Given this list of marker genes BCL7B, TMEM161A, H2AX, NFRKB, SMARCD1, SHLD1, BABAM1, ARID1A, SPIRE1, CBX8, SMARCD2, BRCA1, INO80C, ACTB, EYA3, EGFR, ACTL6B, KAT5, EPC1 (enhancer of polycomb homolog 1), FH, SLF2, SIRT6, FAM168A, CYREN, KMT5C, SIRT1, CEBPG, UBE2V2, SMARCB1, EYA4, BABAM2, SPIRE2, SMARCA2, CREBBP, MARCHF6-DT, TOP2B (DNA topoisomerase II beta), SMARCA4, PNKP, WRAP53, VPS72, ACTR8, NBN, ATM, RUVBL2, ERCC8, PRKDC, MRE11, RPS3, UIMC1, PHF10, MORF4L2, CCDC117, EYA1, RNF8, DPF2, YEATS4, PIAS4, INO80E (NCBI Gene Id 283899), PCNA, HELQ, SHLD3, DMAP1 (NCBI Gene Id 55929), UCHL5, MCRS1, TIGAR, FMN2, BRD8, DPF1 (NCBI Gene Id 8193), SMARCD3, NPAS2, WDR48, KHDC3L, ZCWPW1, EYA2, YY1, SMCHD1, BCL7A, SMARCC2, PELI1 (NCBI Gene Id 57334), DHX9, BRD7, USP1, FOXM1, TIMELESS, EPC2 (NCBI Gene Id 96643), BCL7C, KDM4D, RAD51AP1, FUS, TFPT, RIF1, ACTL6A, ARID1B, MBTD1, ABRAXAS1, BRCC3, STK19 (NCBI Gene Id 8859), SMARCE1, FANCB, PARP3, SKP2, ACTR5, MORF4L1, SETMAR, INO80B, MGMT, PRMT1, INO80D, PRKCG, PARP1, TRRAP, RNF168, DPF3, EP400, AGER, SPIDR, SLF1, WAS, RAD50, ERCC6, ARID2, FGF10, UBE2N, PBRM1, RNF126, ING3, DDX11, INO80, TRIM28, ACTR2, HDGFL2, OOEP, KMT5B, MAD2L2, HDAC10, MRGBP, SMARCC1, MEAF6, MRNIP, SHLD2, HMGB1, RUVBL1, here is a description of the gene set: Human Gene Set: GOBP_POSITIVE_REGULATION_OF_DNA_REPAIR studied in species Homo sapiens Any process that activates or increases the frequency, rate or extent of DNA repair.